The following is a description of a gene set: The appearance of immunoglobulin due to biosynthesis or secretion following a cellular stimulus during an immune response, resulting in an increase in its intracellular or extracellular levels. Human Gene Set: GOBP_IMMUNOGLOBULIN_PRODUCTION_INVOLVED_IN_IMMUNOGLOBULIN_MEDIATED_IMMUNE_RESPONSE studied in species Homo sapiens, and this is the list of marker genes: KMT5B, HSPD1 (NCBI Gene Id 56733), RNF168, PTPRC, PARP3, NSD2, ERCC1, NFKBIZ, AICDA, IL10, RIF1, TP53BP1, ATAD5, SHLD2, TRAF3IP2, PAXIP1, NBN, EXOSC6, CD40LG, SANBR, MSH2, IL4, XCL1 (NCBI Gene Id 92337), STAT6, NDFIP1, SHLD1, BTK, CD40, TNFSF4, SHLD3, SWAP70, TNFSF13, BCL6, IL2, MAD2L2, APLF, IL27RA, SUPT6H, LIG4, UNG, EXO1, KMT5C, PMS2, TFRC, CLCF1, RNF8, PCYT1A, CD28, MLH1, TBX21, BATF, FOXP3, MSH6, CCR6, HMCES, TGFB1, SLC15A4, C17orf99, EXOSC3